Given this list of marker genes KMT2D, ASNS, POMGNT1, GLI2, GMPPB, ELOVL4, MBTPS2, FOXA2, MEF2C, GDF3, LARGE1, EXOC2, AP3D1, EBP, CENPF, ARNT2, IFT74, APC, FKTN, PAX6, ATF6, CDC42BPB, NEU1, PHOX2A, HNRNPK, SLC45A2 (NCBI Gene Id 51151), SOX2, CFAP418, HNRNPU, STAG2, BLOC1S5, CASK, MAFB, POU1F1, MYO5A, COL25A1, DCT, HPS5, TRIM44, KIF21A (NCBI Gene Id 80819), MAF, WT1, SALL4, PRPS1, LHX3, KDM6A, MAP2K2, ZPR1, POGZ, GNAT2, SRD5A3, RSPO2, KIF14, PDE6H, UGP2, HMBS, OTUD5, CACNA1F, ROBO1, ZSWIM6, PTF1A, EPG5 (ectopic P-granules 5 autophagy tethering factor), GPR143, ZFX, PLXNA1, WDR11, CNGA3 (cyclic nucleotide gated channel subunit alpha 3), SLC25A19, SNF8, FZD5, SON, ARSL (NCBI Gene Id 415), ALDH1A2, PPP1CB, PROM1, TUBA8, HPS6, RECQL4, PROKR2, ITPR1, LAMB2, FZD4, ARMC9, MACF1, POMK, RFX7, OCA2, FOXC1, ATOH7, WNT3, KCNK4, SCN8A, MPDZ, GNPAT, RRAGC, LYST, AASS, FKRP, TYR, B3GALNT2 (beta-1,3-N-acetylgalactosaminyltransferase 2, NCBI Gene Id 148789), GDF6, PTPN23, SNAP29, PRPH2, PPP2R1A, FGFR1 (fibroblast growth factor receptor 1), MC1R, LHX4, CDON, RPGR, GRIA4, HMX1, CACNA1C, ANKRD11, SLC38A8, GPR161, NEFL, POLR3A (NCBI Gene Id 11128), SPOP (NCBI Gene Id 8405), FANCI, DNMT3A, DPYD, ATAD3A, CEP85L, POMT2 (NCBI Gene Id 29954), CHN1, OTX2, SIX6, CRPPA, TRIT1, ABCA4, SOX3, MTSS2, TUBA1A, PRR12, IKBKG, RNU4-2, RNF113A, YME1L1, TUBB2B, NFIX, BLOC1S3, PDE6C, RTTN, SETD2, NR2F1, GATAD2B, DDHD2, NDE1, RNF135, CNGB3, RERE, COL18A1, FANCB, GLYCTK, GABBR1, POMT1, EIF4A2, TUBB3, KNSTRN, ZIC1, ERF, HESX1, SLC24A5, ALDH1A3, PIK3CD, PROP1, NDP, TBX4, FDFT1, PUF60, MAB21L1, HPS4, MED12, here is a description of the gene set: Aplasia/Hypoplasia affecting the fundus species: Homo sapiens Human Gene Set: HP_APLASIA_HYPOPLASIA_AFFECTING_THE_FUNDUS